The following is a description of a gene set: studied in species Homo sapiens An abnormality of a masseter muscle. Human Gene Set: HP_ABNORMALITY_OF_MASSETER_MUSCLE Abnormality of masseter muscle, and this is the list of marker genes: RYR1 (NCBI Gene Id 906), NOTCH2NLC, LRP12, RILPL1, CACNA1S, GIPC1